The following is a description of a gene set: electronically inferred by orthology from the curated human pathway Reactome Pathway: ATP sensitive Potassium channels This event has been computationally inferred from an event that has been demonstrated in another species.<p>The inference is based on the homology mapping from PANTHER. Briefly, reactions for which all involved PhysicalEntities (in input, output and catalyst) have a mapped orthologue/paralogue (for complexes at least 75% of components must have a mapping) are inferred to the other species. part of: Inwardly rectifying K+ channels species: Mus musculus, and this is the list of marker genes: Kcnj11, Kcnj8